The following is a description of a gene set: Elevated circulating acylcarnitine concentration Concentration of acylcarnitine in the blood circulation above the upper limit of normal. species: Homo sapiens Human Gene Set: HP_ELEVATED_CIRCULATING_ACYLCARNITINE_CONCENTRATION, and this is the list of marker genes: LYRM7, ETHE1 (ETHE1 persulfide dioxygenase), CPT2, ABCD4, SLC25A20 (solute carrier family 25 member 20), HADHA, ACAD9 (NCBI Gene Id 96656), COX16, SLC52A1, MMACHC, MMAB, ACAD8, MCEE, ACADS, IVD, LMBRD1 (LMBR1 domain containing 1), TANGO2, NADK2, GCDH